The following is a description of a gene set: species: Mus musculus Mouse Gene Set: GOBP_REGULATION_OF_GLIAL_CELL_PROLIFERATION Any process that modulates the frequency, rate or extent of glial cell proliferation., and this is the list of marker genes: Pmp22, Rnf10, Tert, Ifng, Ski, Abcc8, Mtor, E2f1, Plag1, Adcyap1, Sox10, Gfap, Il1b, Lyn, Ptk2, Myc, Prkch, Il6, Sox11, Nf1, Mfn2, Cers2, Trp53, Ascl2, Dicer1, Arrb2, Prkci, Ptn, Tnf, Cysltr2, Ppp1cc, Tspo, Myb, Shh, Rb1, Kras, Nrg1, Notch1, Hes1, Atxn1, Nf2, Vegfc, Mecp2, Slc7a5, Etv5, Cysltr1, Egfr, Fas, Creb1, Cdkn2b, Idh2, Ufl1, Vim, Igf1, Flt1, Ntn1, Lta